Given this list of marker genes SLC26A2, LTBP4, ORC4, FGFR2, MYRF, POR, IL6ST, ORC6, SOX9, IDS, POLR1A (RNA polymerase I subunit A), FLNB, SCUBE3, GMNN, FGFR1, KRT14, KAT6A, MYH11, HRAS, RAC1, ZNF699, ERF, EHMT1, KRT5, here is a description of the gene set: Human Gene Set: HP_BRONCHOMALACIA studied in species Homo sapiens Bronchomalacia Weakness or softness of the cartilage in the walls of the bronchial tubes.